The following is a description of a gene set: Reactome Pathway: Epithelial-Mesenchymal Transition (EMT) during gastrulation During the epithelial-mesenchymal transition (EMT) during gastrulation, epithelial cells in the primitive streak transition to dissociated mesenchymal cells, allowing them to leave the epithelial epiblast. EMT is induced by FGF, WNT, NODAL, and BMP signaling pathways that are present on the posterior side of the embryo. The FGF pathway in particular has been implicated in the regulation of EMT during gastrulation (inferred from mouse embryos in Ciruna and Rossant 2001). In later stage cancer cells the TGFbeta signaling pathway is a major inducer of EMT that leads to metastasis. During gastrulation BMP4 and NODAL of the TGFbeta pathways are also probably involved in EMT.<br>This epithelial-mesenchymal transition (EMT) is responsible for formation of mesoderm. An incomplete EMT appears to be responsible for formation of endoderm (inferred from mouse embryos in Viotti et al. 2014, Scheibner et al. 2021). Prospective definitive endoderm cells leave the epiblast layer together with mesoderm cells and eventually integrate and displace the extraembryonic visceral endoderm layer (inferred from mouse embryos in Viotti et al. 2014).<br>SNAIL (SNAI1), a transcription factor activated in the primitive streak (inferred from the mouse homolog in Carver et al. 2001), participates in crucial events in the EMT that creates mesoderm: the downregulation of cell adhesion proteins E-cadherin (Cadherin-1, CDH1), Occludin (OLCN), and Claudins that results in loss of contact between cells. Instead, cells switch to expression of N-cadherin and mesenchymal gene programs.<br>Both EOMES and TBXT activate expression of SNAI1 at the primitive streak but not in definitive endoderm progenitors. SNAI1 represses CDH1 expression, OCLN expression (inferred from mouse homologs in Ikenouchi et al. 2003), and expression of Claudins (inferred from mouse homologs in Ikenouchi et al. 2003). Downregulation of CDH1 also occurs posttranslationally through an incompletely characterized mechanism involving NIK, p38 MAPK, and EBP41L5 (inferred from mouse homologs in Lee et al. 2007, Hirano et al. 2008). SNAI1 but not SNAI2 is required for proper EMT during gastrulation. Other factors required for EMT during gastrulation include p120-catenin, which regulates WNT signaling and EMT (inferred from mouse homologs in Hernandez-Martinez et al. 2019); Crumbs2, which promotes cell ingression (inferred from mouse homologs in Ramkumar et al. 2016); RhoA and microtubules, which control cell basement interactions (inferred from mouse homologs in Nakaya et al. 2008); and p38 and p38 interacting protein, which are critical for downregulating E-Cadherin. part of: Gastrulation species: Homo sapiens, and this is the list of marker genes: CDH1, SNAI1, FGFR1, TBXT, EOMES, OCLN, CLDN7